Given this list of marker genes PRKAG3, PPARA, BCL2, NPFF, PRKAG2, GHSR, BAX, RXRB, KANK2, SNW1, BBS4, SNAI2, SPX, GHRL, NR1H4, PRKAG1, BBS2, MED1, CARTPT, GHR, RXRA, MN1, LEP, TRIM24, FBN1, GFRAL, UCN, VDR, NENF, CYP27B1, MKKS, NPY, MT3, GDF15, PRKCG, here is a description of the gene set: Any process that modulates the frequency, rate or extent of a response to nutrient levels. species: Homo sapiens Human Gene Set: GOBP_REGULATION_OF_RESPONSE_TO_NUTRIENT_LEVELS